The following is a description of a gene set: Metastatic disease is the primary cause of death in cutaneous malignant melanoma (CMM) patients. To understand the mechanisms of CMM metastasis and identify potential predictive markers, we analyzed gene-expression profiles of 34 vertical growth phase melanoma cases using cDNA microarrays. All patients had a minimum follow-up of 36 months. Twenty-one cases developed nodal metastatic disease and 13 did not. Comparison of gene expression profiling of metastatic and nonmetastatic melanoma cases identified genes with a >2-fold differential expression ratio and a false discovery rate of <0.2 (206 up-regulated and 37 down-regulated). This set of genes included molecules involved in cell cycle and apoptosis regulation, epithelial-mesenchymal transition (EMT), signal transduction, nucleic acid binding and transcription, protein synthesis and degradation, metabolism, and a specific group of melanoma- and neural-related proteins. Validation of these expression data in an independent series of melanomas using tissue microarrays confirmed that the expression of a set of proteins included in the EMT group (N-cadherin, osteopontin, and SPARC/osteonectin) were significantly associated with metastasis development. Our results suggest that EMT-related genes contribute to the promotion of the metastatic phenotype in primary CMM by supporting specific adhesive, invasive, and migratory properties. These data give a better understanding of the biology of this aggressive tumor and may provide new prognostic and patient stratification markers in addition to potential therapeutic targets. species: Homo sapiens Neural-related genes up-regulated in melanoma tumors that developed metastases compared to primary melanoma that did not. Human Gene Set: ALONSO_METASTASIS_NEURAL_UP from publication Alonso SR, Tracey L, Ortiz P, Pérez-Gómez B, Palacios J, Pollán M, Linares J, Serrano S, Sáez-Castillo AI, Sánchez L, Pajares R, Sánchez-Aguilera A, Artiga MJ, Piris MA, Rodríguez-Peralto JL (PMID 17409456), and this is the list of marker genes: MAL, SDCBP, MAGEA6, EMP1, APLP2, AKT1S1, CD63, MITF, S100A10, SELENOP, L1CAM, CHN1, ENC1, PMP22, SETX (senataxin), PDGFRA, PTPRZ1, KIT